Given this list of marker genes RHOA, ARHGEF11, ROCK2, GNA12, LPAR2, ROCK1 (Rho associated coiled-coil containing protein kinase 1), LPAR5, LPAR4, ARHGEF12, LPAR3, LPAR1, ARHGEF1, GNA13, here is a description of the gene set: Pathway Definition from KEGG: LPA -> LPAR -> GNA12/13 -> (ARHGEF12,ARHGEF1,ARHGEF11) -> RHOA -> ROCK1/2 studied in species Homo sapiens LPA-GNA12/13-RhoA signaling pathway. Pathway ID: N01097. Pathway type: Reference. Pathway class: nt06135 Cytoskeletal regulation (viruses and bacteria). Human Gene Set: KEGG_MEDICUS_REFERENCE_LPA_GNA12_13_RHOA_SIGNALING_PATHWAY